The following is a description of a gene set: species: Homo sapiens Myotonia An involuntary and painless delay in the relaxation of skeletal muscle following contraction or electrical stimulation. Human Gene Set: HP_MYOTONIA, and this is the list of marker genes: ATP2A1, KCNE3 (NCBI Gene Id 10008), HSPG2, VAPB, CACNA1S, KCNJ18, LIFR, PFKM, SYNE1, CNBP, KCNA1, HINT1, DMPK, SVIL, VMA21, CAVIN1, ANO5, DNAJB6, LMNA, CACNA1A, ACTA1, SCN4A, CAV3 (NCBI Gene Id 859), UCHL1, FHL1, CLCN1, PURA, SYNE2, EMD, TTI2, SGCG (NCBI Gene Id 6445), GABRA3, TMEM43, COX11